Given this list of marker genes ATP5F1AP1, FRG1HP, ZNG1F, RNU6-156P, RBPJP6, ENSG00000279561, AQP7P5, IGKV1OR9-2, LINC03025, GXYLT1P3, BMS1P14, CDRT15P6 (NCBI Gene Id 100420778), CNTNAP3P7, SDR42E1P2, ENSG00000288891, ADGRF5P2, MEP1AP4, RNU6-1269P, CNN2P4, RN7SL565P, SPATA31A6, RBM17P3 (RNA binding motif protein 17 pseudogene 3), CNN2P2, MIR4477A, RNU6-599P, SNX18P5, FKBP4P6, FAM242F, CDK2AP2P1, CNTNAP3B, RAB28P3, FAM74A7, MEP1AP1, SNX18P8, RPL7AP45, FAM88E, SNORA70, MYO5BP1, CYP4F60P, MIR1299, ENSG00000284116, FGF7P5, FGF7P4, RN7SL343P, FOXD4L6, RNA5SP530, ANKRD20A7P, ANKRD20A2P, FAM95B1, PGM5P2, FGF7P3, CDRT15P14, ENSG00000307235, here is a description of the gene set: studied in species Homo sapiens Human Gene Set: chr9p11